Given this list of marker genes LAMC2, ITGB4, LAMB3, LAMA3, MMP1, KRT5, COL7A1, DSP, COL17A1, here is a description of the gene set: species: Homo sapiens Mitten deformity Fusion of the hands and feet by a thin membrane of skin (scarring) seen in forms of dystrophic epidermolysis bullosa and leading to a \mitten\ hand deformity. Human Gene Set: HP_MITTEN_DEFORMITY